The following is a description of a gene set: from publication Chen Y, Wang X (PMID 31504780) Mouse Gene Set: MIR_21A_3P Genes predicted to be targets of miRBase v22 microRNA mmu_miR_21a_3p in miRDB v6.0 with MirTarget v4 prediction scores > 80 (high confidence targets). studied in species Mus musculus, and this is the list of marker genes: Cript (NCBI Gene Id 80506), Mnt, Rnf38, Taok1, Sypl1, Mtss2, Usp9x, Hmg20a, Tfg, Cyp26b1, Epha5, Ptbp2, Lysmd3, Rybp, Ing2, Pdzd4, Elp1, Dock5, Pcdh15, Gxylt1, Lats1, Tet1, Asap1, Dicer1, Ing3 (NCBI Gene Id 71777), Naa40, Mkrn3, Mis12, Vapa, Smarcad1, Megf10, Col16a1, Ankib1, Nck1, Vapb, Ppfia1, Mynn, Tbx20, Cherp, Zfp207, D430041D05Rik, Abi2, Mtarc2, Kif26b, Neto1 (neuropilin (NRP) and tolloid (TLL)-like 1), Zscan4d, Srsf1, Galnt1, Gimap4, Rrp1b, Cdc14b, Adss2, Cpne3, Klhl4, Timm21, Atl3, Mcm2, Ppig, Epm2aip1, Lats2, Nppc, Pced1b, Usp34, Hlf, Nufip2, Ube2e1, Rpp14, Cacna2d1, Septin11, Atxn1l, Zfpm2, Setd2, Rps6ka6, Cpeb2, Chmp4b, Trim24, Tmem19, Coq8a, Abhd16a, Klhl13, Prom1, Naa50, Slc4a5 (NCBI Gene Id 232156), Tktl1, Cd2ap, Pdxdc1, Ppp1r3c, Spred1, Dennd1b, Etv1, Stx6 (syntaxin 6), Naa15, Oaz1, Rcc2, Srsf2 (serine and arginine-rich splicing factor 2), Rab38, Flrt2, Elovl3, Fbxl21, Fnip2, Cdk19, Tasor2, Tmem167, Top2a, Dhx40, Polq, Spring1, Hic2, Rbm46, Pdgfrb, U2surp, Etl4, Ifih1, Grhl3, Ubqln1, Frs2, Exph5, Avl9, Ssh2, Cyp51 (NCBI Gene Id 13121), Aspn, Bmi1, Rap1b, Amdhd1, Trpc5, Nav1, Thap12, Tardbp, Lamp2, Paf1, Amfr, Eef1b2, Rora, Cul2, Gm8978, Tbc1d8b, Traf5, Dtna, Serpini1, Lipo1, Zscan4c, Slc1a1, Col22a1, Hnf4g, Osbpl6, Msi2, Ryr3, Socs2, Srgn, Bin1, Entpd5, Faxc (failed axon connections homolog), Map2k3, Zfp704, Srsf6, 4933427D14Rik, Fzd6, Calm1, Crebrf, Ptpn12, Inpp1, Nab1 (NCBI Gene Id 17936), Otud4, Gcfc2, Wnt7a, Ube2g2, Kif1b, Fam120a, Synj1, Vsig10l, Spata13, Krit1, Usp37, Fgl2, Smad2, Pcbp2, Ero1b, Rgmb, Tra2a, Kpnb1, Inpp4a (inositol polyphosphate-4-phosphatase, type I), Nlgn1, Gpr37l1, Fgfr1, Oxr1, Zc3h7a, Gm14461, Tyro3, Itga9, Cacnb2, Arf3, Dpp10, Pde1c, Rab33b, Pcdh9, Sema3e, Ap1b1, Pik3ca, Pld5, Dact1 (NCBI Gene Id 66738), Ctnnb1, Rimklb, Rab7, Rdx, Proser2, Atp6v1f, Lrba